Given this list of marker genes STXBP1, SLC35G2, CBLL1, DCX, CAMLG, E2F3, HIPK3, LMAN1, ERLIN1, GABRA6, PTH, SNX3, PDE1C, NCOR2, RPS6KA5, BCR, EIF2AK3, NDUFA5, HINT3, TGFBR1, EFNA3, PRTFDC1, WASL, CDK16, STXBP4, KPNA3, YTHDF3, SLC33A1, DIP2B, TMEM163, AGPS, DSTN, UGT8, STRN3, MGP, DCTN4, DUT, WAPL, CHL1, EYS, SMIM10L1, MEIOC, ZNF662, SMURF2, KCTD12, EPB41L3, LIFR, MFSD1, DMGDH, SLC25A39, SLC2A13, NEFL, ADRB2, GNB4, here is a description of the gene set: Genes predicted to be targets of miRBase v22 microRNA hsa-miR-7702 in miRDB v6.0 with MirTarget v4 prediction scores > 80 (high confidence targets). from publication Chen Y, Wang X (PMID 31504780) Human Gene Set: MIR7702 studied in species Homo sapiens